The following is a description of a gene set: from publication Chen Y, Wang X (PMID 31504780) Genes predicted to be targets of miRBase v22 microRNA mmu_miR_7024_3p in miRDB v6.0 with MirTarget v4 prediction scores > 80 (high confidence targets). species: Mus musculus Mouse Gene Set: MIR_7024_3P, and this is the list of marker genes: Rnf111, Snx12, C9orf72, Slc9a9, Fam120a, Gcc2, Mprip, Zfand3, Dido1, Virma, Socs2, Saraf, F9, Ppm1e (protein phosphatase 1E (PP2C domain containing)), Stx6, Lipg, Gpd1, Notch2 (notch 2), Tra2b, Pxn, Mapk8, Fbln5, Cdc37l1, Homez, Sox6, Etnk1, Hipk3, Slc8a1, Nras (NCBI Gene Id 99853), Atp2b1, Zbtb33, Myrip, Nars2, C1qbp, Clcn3, Usp42, Mtmr3, Kcnc2, Myoz3, Rbm48, Slc13a3, Lars1, Nacc2, Cobll1, Has2, Nmt1, Pym1, Slc5a3, Gpn1, Amy2a2, Rps6kc1 (NCBI Gene Id 98232), Zfp655, Mtnap1, Tmem154, Rarb, Ppp6c, Tubgcp4, Nsd1, Polr3g, Tomm22, Ppp4r3b, Plekhb2, Fdx1, Fgd6, Zmym2 (NCBI Gene Id 76007), Ppargc1a, Lsm12, Nova1 (NCBI Gene Id 664883), Arhgap26, Ehhadh, Slc2a1, Kcnk10, Rab14, Dnaaf3, Ccnyl1, Ces3b, Dpy19l3, Rapgef5, Cdk17, Tbc1d19, Mecom, Errfi1, Naa30, Prrc2b (proline-rich coiled-coil 2B), Srpk2, Etf1, Fryl, Hapln1, Tmem161b, Tmem263, Smyd5, Gpr63, Amy2a3, Prr14l, Zfp1009, Rubcn, Zfp971, Pggt1b (NCBI Gene Id 70264), Pcsk1n, Skil, Nudt4, Tab3, Got1, Slc24a2, Cpped1, Galnt2, Shtn1, Tent4b, Baz2a, Vps13b, Gm14295 (NCBI Gene Id 628084), Chd2 (NCBI Gene Id 77026), Uggt1, Tcaim, Anp32e, Il17rd, Lin28b, Vegfa, Cfap45, Kpna4, Dll1, Gdnf, Kif21b, Glt8d1, Proser1, Amy2a4, Ces3a, Edf1, Cd151, Fign, Rras2, Rbfox1, Afdn, Cpsf4, Sp100, Ncam2, Hmg20a, Traf3, Kcnk3, Itgb8, Stag2, Ppip5k1, Trpm3